The following is a description of a gene set: species: Homo sapiens Signaling by FGFR2 Human Gene Set: REACTOME_SIGNALING_BY_FGFR2, and this is the list of marker genes: HNRNPH1, NCBP2, UBB, PIK3R1, MAPK1, PTBP1, HNRNPM, PIK3CA, POLR2L, SHC1, FGF1, POLR2D, SRC, CBL, PPP2R1A, SOS1, NRAS, GTF2F1 (NCBI Gene Id 2962), BRAF, FGFBP1, FGF2, HNRNPF, NCBP1, TIA1, FGF9, PTPN11, FGF7, POLR2J, FGFR2 (fibroblast growth factor receptor 2), MKNK1, GAB1, POLR2K, ESRP2, POLR2H, GRB2, HNRNPA1, FGFBP3, POLR2E, RBFOX2, FGF20, FGF18, MAPK3, FGF10, POLR2F, FRS3, FGF16, SPRY2, PPP2CB, FGF22, FGFBP2, POLR2I, TIAL1, FGF5, POLR2G, ESRP1, FGF17, KRAS (KRAS proto-oncogene, GTPase), FRS2, FGF4, POLR2A, FGF23, HRAS, RPS27A, POLR2C, POLR2B, UBA52 (ubiquitin A-52 residue ribosomal protein fusion product 1), GTF2F2, UBC, PLCG1, PPP2CA, FGF6, FGF8, FGF3